The following is a description of a gene set: species: Mus musculus The chemical reactions and pathways involving poly-N-acetyllactosamine, a carbohydrate composed of N-acetyllactosamine repeats (Gal-beta-1,4-GlcNAc-beta-1,3)n. Mouse Gene Set: GOBP_POLY_N_ACETYLLACTOSAMINE_METABOLIC_PROCESS, and this is the list of marker genes: B3gnt3, B3gnt9 (UDP-GlcNAc:betaGal beta-1,3-N-acetylglucosaminyltransferase 9), B3gnt4, B4galt5, B3gnt6, B3gnt8, B3gnt7, B3gnt2, B4gat1 (NCBI Gene Id 72430)